The following is a description of a gene set: studied in species Homo sapiens Cycling definitive erythroblast from publication He P, Lim K, Sun D, Pett JP, Jeng Q, Polanski K, Dong Z, Bolt L, Richardson L, Mamanova L, Dabrowska M, Wilbrey-Clark A, Madissoon E, Tuong ZK, Dann E, Suo C, Goh I, Yoshida M, Nikolić MZ, Janes SM, He X, Barker RA, Teichmann SA, Marioni JC, Meyer KB, Rawlins EL (PMID 36493756) Human Gene Set: HE_LIM_SUN_FETAL_LUNG_C3_CYCLING_DEFINITIVE_ERYTHROBLAST, and this is the list of marker genes: CDC6, ARV1, NOP16 (NOP16 nucleolar protein), MTHFD2, ABHD5, ZBTB7A, PAICS, NUSAP1, SPECC1, UBE2T, GTSE1, XK, H3C3, RFC4, MCM4, TYMS, H4C2, DSN1, DDI2, TFRC, KIF22, H4C4, ALAD, ORC1, NCAPH, HJURP (NCBI Gene Id 55355), SLC6A8, RHD, DYNC2I2, NEK2, TTF2, ISOC1, SKA2, UBE2S, HELLS, TLCD4, SLC22A4, TTLL12, CISH, GCDH, CDT1, GCLC, BLM, CCDC18, LDB1, CENPH, HMMR, MZT1, RNASEH2B, UHRF1, H4C12, CPOX, RECQL4, POLA2, NCAPH2, STIL, CENPN, CTSE, CENPW, TF, GPSM2, H2AC8, MGME1, NAA50 (NCBI Gene Id 80218), ACHE, MID1IP1, RCL1, RIPOR3, DNAJC9, ANKRD9 (NCBI Gene Id 122416), RFESD, ATIC, ELOVL6, CENPL, DEPDC1B, SLC7A5, CENPE, CCNE1, PPIF, VRK1, PCLAF, MND1, PCNA, C21orf58, MCM6 (minichromosome maintenance complex component 6), DNAJA4, SPINT2, CENPV, GEN1, FANCA, KMT5A, SNX22, FN3K, CRNDE, HBZ, ABCA7, MCM5, KEL, SLC11A2, CCP110, H2BC15, E2F2, NUP37, ACSL6, C2orf88, CDKN3, LPCAT3, BUB1B, NUF2, H2BC9, C17orf99, BLVRA, GALNT6, PKMYT1, DSCC1, EPCAM, HBQ1, H3C10, PPME1, S100A4, TRIM10, HIC2, ARHGEF39, H2AC13, CKS2, EXO1, NEIL3, ASF1B, KIF18A, TRIP13, PIP5K1B, KLF1, KMT5C, SYNGR1, MLH1, TTPAL, MELK, CKAP2L, SPN, SLC25A38, OSBP2, GMNN, UBAC1, H4C6, KCTD9, AEN, CCNA2, ISG20, ERI1, CMPK2, CHAC2, FKBPL, TSPAN17, H2AC17, H1-3, CDC45, RHAG, H2AC12, KNL1, MKI67, SGO2, FAM72B, STEAP3, PBK, AURKB, PCK2, CR1L, RAB3IL1, PAK1, SPC24, FAM178B, CDCA4 (NCBI Gene Id 55038), C8orf88, NUP210, FANCI (NCBI Gene Id 751608), AQP3, CDCA3 (NCBI Gene Id 83461), YEATS4, NMNAT3, EZH2, GFI1B, ZWINT, CENPA, TSPO2, SPTA1, MYL4, GYPA, RABGAP1L, ATAD2, ADISSP, TPX2, ECT2, MACIR, AURKA, H2BC7, TOP1MT, AGO2, IKZF1 (IKAROS family zinc finger 1, NCBI Gene Id 55429), LRR1, SMIM1, MST1, GINS2, KREMEN1, EXOSC9, KIF20A, TK1, TRAK2, H2AC20, PRIM1, H2BC11, NCEH1, KPNA2, JAZF1, H2AC4, LIG1, RMI2, DHFR, HEMGN, ATG4D, SLC1A5, PCCB, CDCA2, MAD2L1 (mitotic arrest deficient 2 like 1), SSX2IP, CKAP2, BRCA2, LNPK, SLC6A9, H1-5, ACKR1, CHST2, CD44, TIMM8A, H2AC14, H3C15, PPOX, CENPP, H2AC16, GCLM, WDR76, ART4, DBF4, SPTB, CDK1, SOX6, HES6 (hes family bHLH transcription factor 6), PARPBP, ESCO2, ANKLE1, FAM117A, RFC5, MIGA2, TANGO2, DIAPH3 (NCBI Gene Id 81624), CDKN2C, GRK6, SLC25A21, CEP43, KIF15, DNAJC6, SMC2, MFHAS1, DLGAP5, CCNF, MXD3, ERMAP, CENPU, KCNN4, POLQ, LIN52, SMIM5, APOBEC3B, WDHD1, IQGAP2, TSPAN32, WDR4, FARSB, SKA3, NDC80, WRN, ELL2 (NCBI Gene Id 22936), ANK1, KIF11, RAD54L, TFDP1, SHCBP1, H2BC18, DLEU2, H4C11, BOP1, BRCA1, NSD2, ACSS1, RNF123, SPC25, NCAPD2, FOXM1, NUDT1, CHEK1, RAD51AP1, PRR5, LRRCC1, EXOSC3, FERMT3 (NCBI Gene Id 83706), CDC20, MFSD2B, MYCBP, EEF1E1, GATA1, DEPDC1, LHPP, MYBL2, SFXN4, C2orf69, SNHG10, NCAPG, RACGAP1, HPRT1, TESC, ATAD5, H2BC4, H2AC11, H3C2, SLC37A4, SLC38A5, PRPS2, FAH, KIFC1, PRC1, CDCA8, RMDN3, SLC22A16, SLC20A1, RPS6KB2, E2F8, FAM72A, CHPT1, DHRS13, RGS10, DPP7, CKS1B, CPVL, PAK1IP1, ARHGAP11A, KCNH2, ORC6, KNSTRN, RCCD1, CYBRD1, HBB, NCAPD3, PKLR, RRM2, SKA1 (spindle and kinetochore associated complex subunit 1), CCNB2, MCM2 (minichromosome maintenance complex component 2), MINPP1, CCDC34, KIF4A, ZWILCH, RAB6B, PIGQ, FEN1, SMAP2, UBE2C (NCBI Gene Id 11065), CENPF, FAM83D, CCNB1, HMGN5, SPAG5, H2BC3, TOP2A (NCBI Gene Id 7153), PLEK2 (NCBI Gene Id 26499), CIP2A, GYPB, EPB42, MCM10, AGPAT5, TMEM86B, SLC43A3, MTHFD1, ITGA4, SLC48A1, MIS18A, DONSON, DPF3, BRI3BP, POC1A, SGO1, RBL1, TROAP, NCAPG2, TACC3, BTG3, APOBEC3C, CHAF1A, ABCB10, CENPM, TTK (NCBI Gene Id 7272), CHEK2, EPOR (NCBI Gene Id 2057), CEP152, TMOD1, MRC2, DCLRE1B, ADD2, SLC43A1, RRM1, CLSPN, C9orf40, MYC, ABCB8, PMM1, ICAM4, CDCA5, RFC3, KIF20B, ANLN, ASPM, CD82, CA8, CENPK, PLK1, POLD1, PRMT3, FHDC1, H3C8, PGP, KIF2C, KIF14, PTTG1, OIP5, AMMECR1, BUB1, APEH, TUBB1, PRKAR2B, TFR2, BIRC5, ATP1B2, SASS6, RHCE, MPHOSPH9, GYPE, PLK4, FBXO5, NFE2, KIAA1586, KIF23, SNRNP25